Given this list of marker genes FGF1, FGF8, FGF2, FGF6, FGF20, POLR2I, GTF2F2, POLR2G, FGF4, POLR2F, FGF7, FGF18, FGF23, FGF5, POLR2A, POLR2B, FGF22, FGF3, FGF9, FGF10, POLR2E, NCBP1, POLR2C, FGFR2, POLR2L, POLR2K, FGF17, FGF16, POLR2H, NCBP2, POLR2J (NCBI Gene Id 5439), GTF2F1, POLR2D, here is a description of the gene set: Human Gene Set: REACTOME_FGFR2_MUTANT_RECEPTOR_ACTIVATION FGFR2 mutant receptor activation studied in species Homo sapiens